The following is a description of a gene set: The chemical reactions and pathways resulting in the breakdown of heparan sulfate proteoglycans, which consist of a core protein linked to a heparan sulfate glycosaminoglycan. The heparan sulfate chain is composed of the repeating disaccharide unit beta-(1,4)-N-acetyl-D-glucosamine-alpha-(1,4)-hexuronic acid, the former being either sulfated or deacetylated on its amino group as well as sulfated on one of its hydroxyl groups, and the latter being a mixture of sulfated and nonsulfated D-glucuronic and L-iduronic acids. studied in species Mus musculus Mouse Gene Set: GOBP_HEPARAN_SULFATE_PROTEOGLYCAN_CATABOLIC_PROCESS, and this is the list of marker genes: Hgsnat, Naglu, Gpc1, Gns, Idua, Ctsl, Ids, Sgsh, Gusb, Hpse